Given this list of marker genes MC2R, CYP11A1, NR0B1, NR3C1, AIP, CYP11B1, TP53, GMPPA, MRAP, AAAS, USP48, POR, ATRX, TRAPPC11, NNT, GNAS, BRAF, USP8, CDH23, here is a description of the gene set: Increased circulating ACTH level studied in species Homo sapiens An abnormal increased in the concentration of corticotropin, also known as adrenocorticotropic hormone (ACTH), in the blood. Human Gene Set: HP_INCREASED_CIRCULATING_ACTH_LEVEL